Given this list of marker genes Cyba, Atp6v1f, Tcirg1, Slc11a1, Atp6v1g3, Atp6v0e2, Nos2, Rac2, Atp6v1d, Atp6v0e, Atp6v1a, Atp6v0a4, Atp6v0d1, Atp6v0c, Lpo, Atp6v0a1, Atp6v1c2, Ncf1, Atp6v1e2, Atp6v1g2, Ncf2, Hvcn1, here is a description of the gene set: electronically inferred by orthology from the curated human pathway studied in species Mus musculus Reactome Pathway: ROS and RNS production in phagocytes This event has been computationally inferred from an event that has been demonstrated in another species.<p>The inference is based on the homology mapping from PANTHER. Briefly, reactions for which all involved PhysicalEntities (in input, output and catalyst) have a mapped orthologue/paralogue (for complexes at least 75% of components must have a mapping) are inferred to the other species. part of: Innate Immune System